The following is a description of a gene set: Any process that modulates the frequency, rate or extent of receptor localization to synapse. Human Gene Set: GOBP_REGULATION_OF_RECEPTOR_LOCALIZATION_TO_SYNAPSE studied in species Homo sapiens, and this is the list of marker genes: TYROBP, HRAS, GPC4, MAP2K1, GRIPAP1, VPS26B, ADAM10, CACNA2D2, STX7, DBN1, RAP1A, TMEM108, ZDHHC3, CPLX1, EPB41L3, GPC6, DAG1, GABARAP, ZDHHC2, GHSR, KIF2C, ARHGAP44, RDX, NPTN, NETO2, ITGB3, OGT, OLFM1, IQSEC2, TRAF6